The following is a description of a gene set: species: Homo sapiens A type of keratitis characterized by inflammation in pinpoint areas of the corneal epithelium. Punctate keratitis Human Gene Set: HP_PUNCTATE_KERATITIS, and this is the list of marker genes: EPCAM, PLEC, PERCC1, GJB2, ATP2A2, NLRP1, GJB6 (NCBI Gene Id 1897)